Given this list of marker genes ABCB1, SLC5A2, ABCC3, RALBP1, SLC5A1, SLC50A1 (solute carrier family 50 member 1), here is a description of the gene set: species: Homo sapiens Human Gene Set: GOBP_GLYCOSIDE_TRANSPORT The directed movement of a glycoside into, out of or within a cell, or between cells, by means of some agent such as a transporter or pore.